The following is a description of a gene set: studied in species Mus musculus Mouse Gene Set: GOBP_NEGATIVE_REGULATION_OF_STEROL_TRANSPORT Any process that stops, prevents, or reduces the frequency, rate or extent of the directed movement of sterols into, out of or within a cell, or between cells, by means of some agent such as a transporter or pore., and this is the list of marker genes: Apoe, Nfkbia, Apoc2, Apoc3, Adipoq (adiponectin, C1Q and collagen domain containing), Abca2, Apoc2l, Srebf2, Shh, Pcsk9, Egf, Irak1, Apoc1, Pla2g10, Apoa2